Given this list of marker genes PM20D1, C1QTNF4, CD36, PRLH, GFRAL, PASK, MAPK14, CEBPA, UCP1, NMU, TBL1XR1, SCTR, NR4A3, FMO2, BOLA3, TRPV1, SQSTM1 (NCBI Gene Id 94002), PRKAA1, WNK4, EIF4G1, RRP8, ALK, STAT3, FMO1, SUCNR1, FOXO1 (NCBI Gene Id 2308), PPARGC1B, MEX3C, TWIST1, MFSD2A, MRAP2, LEPR, CRTC3, PPARGC1A, GUCA2B, ADRB1, MAPK8, SCT, LEP, NMUR2, SLC25A25, SUV39H1, STK39, ACACB, RASAL2, CNTN2, GDF3, AMPD2, APOE, TMEM18, MLXIPL, RMI1, DLL1, ADRB3, ACVR1C, PRCP, PPRC1, GPR82, SIRT1, SLC35D3, BMP8A, COL6A1, PRKAA2, PPARD, PIK3CA, APPL2, GDF15, ADRB2, METRNL, TRPV4, UBB, IRX3, VGF, FMO4, FLCN (NCBI Gene Id 201163), CRTC1, OMA1, BMAL1, TSKU, PCSK1N, LIPA, SGIP1, IGF2BP2, SORL1, CCDC198, NR1D2, EDN2, here is a description of the gene set: species: Homo sapiens Human Gene Set: GOBP_ENERGY_HOMEOSTASIS Any process involved in the balance between food intake (energy input) and energy expenditure.